The following is a description of a gene set: studied in species Homo sapiens Human Gene Set: GOBP_THIAMINE_CONTAINING_COMPOUND_METABOLIC_PROCESS The chemical reactions and pathways involving thiamine (vitamin B1), and compounds derived from it., and this is the list of marker genes: SLC19A2, ACP3, SLC19A3, SLC25A19, THTPA (thiamine triphosphatase), TKTL1, TPK1